The following is a description of a gene set: A process in which a host organism modulates the frequency, rate or extent of any of a process being mediated by a virus with which it is infected. studied in species Homo sapiens Human Gene Set: GOBP_MODULATION_BY_HOST_OF_VIRAL_PROCESS, and this is the list of marker genes: RAB5A, DDX56, CDC42, ZC3H12A, ZDHHC9, EEA1, FBXL2, LTF, EIF2AK4, YTHDC2, PAIP1, FMR1, APOE, NUCKS1, PI4KA, PPIB, ZFYVE1, CCL8, VAPB, PIK3C3, APOBEC3H, CAV2, TMEM41B, MIR221, EEF1A1, CCNK, CSF1R, ZNF502, ZBED1, FASN, STOM, ROCK2, PC, ZDHHC20, PIK3C2G, PSMC3, MIR222, ZDHHC8, CFL1, SMC5, TBC1D20, IGF2R (NCBI Gene Id 3482), PRKN, VAPA, IFI27, RAB29, APCS, PHB1, PTX3, SMC6